The following is a description of a gene set: from publication Amit I, Garber M, Chevrier N, Leite AP, Donner Y, Eisenhaure T, Guttman M, Grenier JK, Li W, Zuk O, Schubert LA, Birditt B, Shay T, Goren A, Zhang X, Smith Z, Deering R, McDonald RC, Cabili M, Bernstein BE, Rinn JL, Meissner A, Root DE, Hacohen N, Regev A (PMID 19729616) mouse primary BMDCs were stimulated with tlr ligands and gene expression changes were profiled on Affymetrix arrays Genes down-regulated in comparison of dendritic cells (DC) stimulated with LPS (TLR4 agonist) at 24 h versus DC cells stimulated with Pam3Csk4 (TLR1/2 agonist) at 24 h. studied in species Homo sapiens Human Gene Set: GSE17721_LPS_VS_PAM3CSK4_24H_BMDC_DN, and this is the list of marker genes: LRFN1, POSTN, RAB7A, PAG1, PDHB, RAB34, MGAT2, PRXL2B, CKLF, CALCRL (NCBI Gene Id 10203), SAPCD1, TRAPPC2L, PGK1, GYS1, BCL6, SQOR, MYO1B, NKX2-2, RAD51 (NCBI Gene Id 5888), NDUFB2, MRPL33, CHCHD10, YPEL3, DOLPP1, GPR85, CLINT1, GPSM3, TNNI2, RAB3D, PECAM1, PON2, LANCL2, NDUFB5, PSMA6, RAB27B, PPP1R3A, MVD, SPOCK2, CST9L (NCBI Gene Id 128821), GRK5, TPBG, STMN1, RRAS, SELENOH, FNBP1, CLYBL, ADAM9, RPL12, PPP1R14B, ABCE1, TSPAN14, S100A13, SIPA1, STOM, ACTR3, RCAN3, ALDOA, SEPTIN9, SVIL, NOMO1, YBX1, FH, IARS1, RSPH3, CAMK1D (calcium/calmodulin dependent protein kinase ID), CCDC80, PTBP3, MCUB, MAT2A, NCAPH, MICAL1, PEA15, DPAGT1 (dolichyl-phosphate N-acetylglucosaminephosphotransferase 1), TSHZ2, LGALS1, MRPS14, RPS15A, PRKAG1, ST6GAL1, GK, PFKL, LAMTOR1, ENO3, ADCY7, SS18L2, ELOVL1, SMC3, LUZP1, SMC1A, COX8A, NSDHL, HPF1, TRIM69, MTHFD1, CEND1, HNRNPLL, SHE, CTDSP2, ABHD17A, ESYT3, MAPK11, ZFHX3, UBALD1, DBNDD1, STAMBPL1, ATP6AP2, HSD17B12, RPS14, TMEM38B, PALD1, RPS4X, MMP7, GSN, PPIB, CDH5, FCGR2A (NCBI Gene Id 90764), PSMG1, DDX39B, STARD7, FOXB1, BSCL2, UBE2J1, RNF38, ETHE1, EWSR1, PLAUR, PLP2, HIP1, MYO7A, EMILIN1 (NCBI Gene Id 25883), SSBP4, SDC2, SLAMF9, SLC66A2, PTPRK, SREBF2, SH3BGR, SLC25A29, TXNDC16, VSIR, GPSM2, BCAM, ARHGAP4, HAUS1, ZW10, MORN3, TNK1, PLEKHA6, CD300C, RNF128, PILRA, GSTM3, TIMM8A, CENPE, NPEPL1, IL16, FGR, SPARCL1, DOK3, TPST2, TNPO2, LIMD2, ABCB6, MOB1A, ABL1, HSD17B7, GNG2, SEC61B, CENPC, UQCR11, NDUFV2, TMEM268, NDUFA3, TP53INP1, ACOT7, ICE1, PROM1, SLC12A6, AKR1B15, BNIP1, KCTD11, ZNF740 (zinc finger protein 740), PUS7, KCTD1, LSS, BLMH, SRSF9, KIF20A, GAK, NAB2, SLC12A7, FOXD4L1, SMC4, DHCR24, ARMH4, ACADVL, NCAPD2, SLC4A4, ANAPC13, HMGCR